Given this list of marker genes KRAS, DHCR24, GHR, TRIP11, DBR1, here is a description of the gene set: species: Homo sapiens Hypoplastic nasal bridge Human Gene Set: HP_HYPOPLASTIC_NASAL_BRIDGE